The following is a description of a gene set: Human Gene Set: HP_PTERYGIUM Pterygia are 'winglike' triangular membranes occurring in the neck, eyes, knees, elbows, ankles or digits. studied in species Homo sapiens Pterygium, and this is the list of marker genes: MMP2, FKBP10, RIPK4, MYH3, NUP88, PLEC, GPC6, CHUK, ERCC2, SLC18A3, ALPK3, HSPG2, FLVCR2, ERCC3, PLOD2, MUSK, RAPSN, DDB2, TUBA1A, PAX3, CCN2, ERCC4, DKC1, CHRNA1, ERCC5 (ERCC excision repair 5, endonuclease), ITGB4, POLR1A, TAF4, IRF6, IRX5, LMX1B, PITX1, IGF2 (NCBI Gene Id 492304), ITGA6, MYOD1, MAGEL2, BHLHA9, CHRND, XPC, NOP10 (NOP10 ribonucleoprotein), EFNB1, NHP2, CHRNG, KIF21A, ADGRG6, PHGDH, KIF14, MMP14, XPA, DOK7